The following is a description of a gene set: Mouse Gene Set: GOCC_NEUROMUSCULAR_JUNCTION species: Mus musculus The junction between the axon of a motor neuron and a muscle fiber. In response to the arrival of action potentials, the presynaptic button releases molecules of neurotransmitters into the synaptic cleft. These diffuse across the cleft and transmit the signal to the postsynaptic membrane of the muscle fiber, leading to a change in post-synaptic potential., and this is the list of marker genes: Rock2, Pls3, Musk, Pdzrn3, Stxbp5l, Chrna1, Rph3a, Psen1, Sarm1, Nrxn1, Snta1, Dlg1, App, Ptn, Efna2, Crkl, Erbb4, Unc13b, Dnaja3, Akap1, Kcnn3, Cdh15, Crk (v-crk avian sarcoma virus CT10 oncogene homolog), Cav3, Unc13c, Ascc1, Fchsd2, Lama5, Lama2, Camk2d, Unc13a, Gria1, Chrne, Erbb2, Cd2ap, Vamp1, Dlg2, Kcnc3, Rapsn, Prkcq, Slc5a7, Ache, Stx1b, Thbs4, Nefl, P2rx7, Stxbp5, Napa, Syngr1, Adora3, Colq, Utrn (utrophin), Cdk5, Des, Large1, Apbb1, Syt2, Erbin, Col4a5, Dlgap4, Postn, Syp, Dlg4, Lamc1, Cyth1, Ank3, Lrp4, Nrg1, Lama4, Nlgn1, F2r, Dlgap3, Pclo (piccolo (presynaptic cytomatrix protein)), Trip4, Dlg3, Syngr4, Cib2, Syngr2, Prkce, Prkaca, Tbc1d24, Slc8a3, Cdk5r1, Chrnd, Myh10, Dok7, Itga7, Chrnb1, Syngr3, Fchsd1, Lamb2 (laminin, beta 2), Myh9, Ngfr, Itgb1, Epha7, Nefm, Ppp1r9a, Dock7, Serpine2, Epha4, Cxadr, Sv2a, Slc18a3, Itga3, Spock1, Sync, Kcnc4, Hdac4, Dnajc5, Tuba1a, Prkar1a